Given this list of marker genes TBC1D19, SERPINI1, HLCS, IRF8, PTPN6, TMLHE (trimethyllysine hydroxylase, epsilon), NDUFA7, FAM216A, RNF128, ARHGDIB, TULP3, RDH12, CD1D, RIDA (NCBI Gene Id 137671), MGST2, NAB1, PRKCB, TCEAL9 (transcription elongation factor A like 9), MAP2K6, FBXW2, DGAT2, TMEM126A, MRPL45, CHAC1, CD300LD, DNAJC18, MRAS, BCKDHA, RAMAC, GLG1, KDM3A, MAGED1, MID1IP1, MAP1LC3A, SELENOM, DGCR6, GOT2, C1S, LIF, SCPEP1, AMACR, FRK, PSD3, SYT11 (synaptotagmin 11), KLRD1, SPN, PTPN21, TBCE, ANAPC1, NDUFA4, MYO1B, COL19A1, SERP1, CFAP68, CCDC71, POLR1D, SPICE1, KIAA1143, TMUB2, SLC39A4, TSPO, CCNDBP1, HTATIP2, SLAMF9, OAZ1, IGFBP4 (NCBI Gene Id 3487), IFTAP, GAB2, HACL1, COX7A2L, SSX2IP (NCBI Gene Id 22892), HIBCH, PFKL, DOK3, MMP9, HMMR, TFPI, TPD52L2, MPLKIP, EMB (NCBI Gene Id 133418), CLEC4D, FADS1 (NCBI Gene Id 3992), CYB5R4, ARL3, CDKN2D, MRPL33 (NCBI Gene Id 9553), NQO1, HLA-DOA, CWC27, OXLD1, SKP1, PPEF2 (NCBI Gene Id 5470), TM4SF5, EBAG9, TP53I13, SERF2, ZNF821, LAMP2, CYP1B1, OLFML3, PIM2, SLPI, PTDSS2, TESK2, TP53INP2, VEGFC, CTSF, LRBA, ITFG1, CYRIB (CYFIP related Rac1 interactor B), NF2, OSGIN1 (oxidative stress induced growth inhibitor 1), GAS2, DDT, PABPC1, ETV1, GCLC, GSTT2, DHRS1, GANC (glucosidase alpha, neutral C), FKBP7, PTEN (NCBI Gene Id 8037), MAP1LC3B, PIK3CG, EXT2, SHISA2, CDK5RAP1, CD2BP2, PGAM1, ACP5, MBOAT7, ZC3H14, DGAT1, SPIDR, SLC25A10 (solute carrier family 25 member 10), CCDC107, GRINA, MFSD6, PLBD1, SLC6A9, GJA1, DHX57, C3, FXYD2, HSD11B1, C1R, TGFBI, CFAP410, MGST1, ATOX1, PRDX2, UFSP2, ALDH2, TAL2, DCN, ITM2B, FAM32A, GSDME, SNHG8, LIMD2, RRAS, CPNE3, FAM120B, MYCBP, SMIM14, SOD1, KIF1B, SARAF, PLCB4, SEC14L1, OAZ2, TNFSF13B, CREG1, NCAPH, HACD3, GSTA5, NOCT, BCAP31, LAMTOR2, CHST1, AGPAT5, TUBGCP4, LTC4S, ABCB4, CD52, CX3CR1 (C-X3-C motif chemokine receptor 1), TPRG1L, CBR1, TMEM119, HPRT1, ENPP2, RAB13, PLRG1, PRG4, WIPI1, MMD, ABCC3, NPY, CD37, SCP2, here is a description of the gene set: Human Gene Set: GSE17721_ALL_VS_24H_PAM3CSK4_BMDC_DN Genes down-regulated in comparison of dendritic cells (DC) stimulated with Pam3Csk4 (TLR1/2 agonist) at all time points versus those stimulated with Pam3Csk4 (TLR1/2 agonist) at 24 h only. from publication Amit I, Garber M, Chevrier N, Leite AP, Donner Y, Eisenhaure T, Guttman M, Grenier JK, Li W, Zuk O, Schubert LA, Birditt B, Shay T, Goren A, Zhang X, Smith Z, Deering R, McDonald RC, Cabili M, Bernstein BE, Rinn JL, Meissner A, Root DE, Hacohen N, Regev A (PMID 19729616) species: Homo sapiens mouse primary BMDCs were stimulated with tlr ligands and gene expression changes were profiled on Affymetrix arrays